Given this list of marker genes NFKB1, IKBKG, NFKBIA (NCBI Gene Id 4792), CHUK, NFKB2, IKBKB, RELA, here is a description of the gene set: IkBA variant leads to EDA-ID studied in species Homo sapiens Human Gene Set: REACTOME_IKBA_VARIANT_LEADS_TO_EDA_ID